Given this list of marker genes PTH2R, RRP9, GAP43, PARD6A, KEAP1, MYOM1, TTLL1, CGB3, GLI1, LILRA4, SELE, NELL1 (NCBI Gene Id 4745), ZNF516 (zinc finger protein 516), CD48, CH25H, RBFOX2, MIR9-1HG, PDLIM4, CCL21, ICA1, BIK, KRTAP5-9, PLCH2, COL7A1, CXCL13, ZNF24, GUCA2B, ALPI, DLK1 (delta like non-canonical Notch ligand 1), GDPD5, KIT (NCBI Gene Id 5086), IL15RA, GRIK2, KLHDC3, THBS4, ITGA2, PRSS2, GCGR, PLA2G7, HBZ, ALDH3B2, B4GAT1, ENPP2, KCNJ10, FKBP6, TP53TG1, TNNT3, ELAC2, PUM3, CYP2J2, GREB1, CCL17, RRH, PROCR, RASL10A, SLC11A2, HMOX1, TIMM17B, QPRT, PSMD13, ENTPD3, DLC1, MTMR11, PEX5, RAB11B, PPFIBP1, MXD4, FARP2, CDX1, CDKN1B, CHI3L1, IGF1, URB2, DEFA5, PCDHA9, CDC42EP2, PITX1, SPINK1 (serine peptidase inhibitor Kazal type 1), TRH, STMN2 (NCBI Gene Id 11075), PTPRO, AGXT, SCG2, HBB, CARD8, FABP4, SCGB1A1, STAT2 (signal transducer and activator of transcription 2), SPOCK1, DUSP4, NR2F6, GPRC5B, APOL1, TPST1 (tyrosylprotein sulfotransferase 1), OVOL2, INSM1, KCNQ1, ARHGEF5, CHPF, ATF3, ROR1, NR4A2 (NCBI Gene Id 4929), CCN3, ACP5, HNF1B, IER3 (immediate early response 3), ACVR2A, COL9A2, AQP8, PRKCQ, AOAH, AQP4, ADRA1D, ACACB, PEX14, BCAS1, STEAP1, KCNQ3, HOXB7, GCLM, F2RL1, GSTZ1, UMOD, ME1, HOXB13, HMGB3, KLHL25, VLDLR, EFEMP2, IGSF6, HSD11B1, MAMLD1, B3GALT4, GNG12, ALOX15, RUNX1T1, VAV2, ATP2B4, SPRR1B, ABHD2, ELL2, FGFBP1, DUSP2, MAP2K5, PDCD1, TEP1, PCP4, ACSL4, PCBP4, PMEL, ELN, ITPKA, SH2D2A, ZNF324, SKAP1, OPRK1, ADH1A, ARL4C, CDH22, PCDH1, DHODH, CILP, NET1, CHN2, GNL1 (NCBI Gene Id 285831), KLRC3, RNF40, TFF3, SNCB, MMP10, DDT, LDAF1, PRLR, CLEC10A, CELF2, AP3S2, CSTF2, CTSO, AMPH, SYMPK, CDT1, SLC27A2, GLRA1, RND1, LY6H, CXCL10, ABCC4, DRD4, MOK, CCNE1, SLC49A3, TRPC4AP, H2BC11, ADARB1, PTPN13, C1R, KLRC2, PNOC, BCL2A1, ARHGAP32, TGFBR3, DDX42, GATM, MFGE8, S100A1, WFDC2, ICAM3, CABP1, NFKBIB, EGR3, PDGFRA, CPLX2, CTSE, GABRG2, RXRG, KCNC3, MAOB, APLP1 (amyloid beta precursor like protein 1), RGS2, HSPBP1, ATP7B, CACNG3, REG1B, RNASE2, GAGE12F, LAMB3, EVI2A, HYAL1, ZNF646, SEPTIN5, PCYT2, PPP2R3A, SELENOP, SLC25A16, CAPN3, KYAT1, SLC22A18AS, MYOG, ECD, RAPSN, SCO2, NDN, EGR2, IGFBP3, LHB, ARHGEF11, NKX2-8, INPP4A, ARMCX2, RUNX1, TFF1, MT1L, SDS, EPHB1, RYR1, COL2A1, IL1R1 (interleukin 1 receptor type 1), RAB40B, RIMS3, ITGB4, AOC1, SETD2, MAP3K13, ADM, PDLIM7 (PDZ and LIM domain 7), SMARCD3, ROS1, ITGB7, AGA, TCN1, BTNL3, RASGRP1, CHL1, CR2, GAGE12G, TEAD4, DAPK1, EML2, FYB1, EPS8, TOM1L1, EXPH5, DIO2, CDON, VDR, SH2B2, NUP58, ARHGAP8, ARNT2, RAI14, ANAPC15, NR2E3, OLFM4, TYRO3, EPHB2, APBB1, KRT18, KDELR3, DYNC2LI1, C6, SELP, TLE4, SBNO2, CHRNB3, EFNA4, ACY1, PACSIN2, AQP9, AMELY, HLA-DOA, ABCF3, GPR183, JUN, PLEKHA6, PLS1, EDA, RAB4B, CNTNAP2, TBX5, GALNT10, CAV1, MYL4, KIAA0040, IL27RA, GPR20, SOCS2, CHGA, NKX3-1, APBA1, PSMG1, TRPM2, TYRP1, POLR1C, PFKL, LHX2, PEMT, CD1C, RECQL4, RBMS3, CYP2C19, HES1, IL3, SARDH, GRIN1, F12, GPKOW, GART, SIX6, CRELD1, FGF9, RCC1, ABCA3, FUT6, CCK, TARBP2, PTPRE, AGAP1, CDH5, COL5A2, EPHX2, KRT14, IRF8, AKAP7, PSEN2, PMVK, ASPH, C4BPB, RFX2, GRIK1, HOPX, NPAS1, HRC, SERPINI1, SETD4, here is a description of the gene set: studied in species Homo sapiens Human Gene Set: MODULE_94 Signaling.